The following is a description of a gene set: The tooth development process in which the teeth enter the mouth and become visible. Mouse Gene Set: GOBP_TOOTH_ERUPTION studied in species Mus musculus, and this is the list of marker genes: Tcirg1, Snx10, Ift80, Ccdc154, Fam20a (NCBI Gene Id 208659), Tnfsf11